Given this list of marker genes Clec4n, Ccl7, Ywhag, Tuba1b, Eif4a1, Ccl9, Ccl6, Ccl2, Ptpn1, Socs3, Flot1, Ccl12, Nxn, here is a description of the gene set: Genes positively differentially expressed in cell type: Macrophage upon treatment with cytokine: IL-10 in mouse lymph nodes in vivo. studied in species Mus musculus from publication Cui A, Huang T, Li S, Ma A, Pérez JL, Sander C, Keskin DB, Wu CJ, Fraenkel E, Hacohen N (PMID 38057668) Cytokines mediate cell-cell communication in the immune system and represent important therapeutic targets. A myriad of studies have highlighted their central role in immune function, yet we lack a global view of the cellular responses of each immune cell type to each cytokine. To address this gap, the authors created the Immune Dictionary, a compendium of single-cell transcriptomic profiles of more than 17 immune cell types in response to each of 86 cytokines (>1,400 cytokine-cell type combinations) in mouse lymph nodes in vivo. A cytokine-centric view of the dictionary revealed that most cytokines induce highly cell-type-specific responses. For example, the inflammatory cytokine interleukin-1β induces distinct gene programmes in almost every cell type. A cell-type-centric view of the dictionary identified more than 66 cytokine-driven cellular polarization states across immune cell types, including previously uncharacterized states such as an interleukin-18-induced polyfunctional natural killer cell state. Mouse Gene Set: CUI_MACROPHAGE_IL10_RESPONSE_UP